The following is a description of a gene set: Wnt signaling in adult hippocampal neurogenesis Human Gene Set: WP_WNT_SIGNALING_IN_ADULT_HIPPOCAMPAL_NEUROGENESIS species: Homo sapiens, and this is the list of marker genes: NEUROD1, FZD3, NEUROG2, WNT3A, CCND1, FZD1, WNT5A, PROX1, WNT7A, WNT3, LRP6